The following is a description of a gene set: species: Homo sapiens from publication Coller HA, Grandori C, Tamayo P, Colbert T, Lander ES, Eisenman RN, Golub TR (PMID 10737792) MYC affects normal and neoplastic cell proliferation by altering gene expression, but the precise pathways remain unclear. We used oligonucleotide microarray analysis of genes and expressed sequence tags to determine changes in gene expression caused by activation of c-MYC in primary human fibroblasts. In these experiments, genes were consistently induced, and genes were repressed. The identity of the genes revealed that MYC may affect many aspects of cell physiology altered in transformed cells: cell growth, cell cycle, adhesion, and cytoskeletal organization. Identified targets possibly linked to MYC's effects on cell growth include the nucleolar proteins nucleolin and fibrillarin, as well as the eukaryotic initiation factor 5A. Among the cell cycle genes identified as targets, the G1 cyclin D2 and the cyclin-dependent kinase binding protein CksHs2 were induced whereas the cyclin-dependent kinase inhibitor p21(Cip1) was repressed. A role for MYC in regulating cell adhesion and structure is suggested by repression of genes encoding the extracellular matrix proteins fibronectin and collagen, and the cytoskeletal protein tropomyosin. A possible mechanism for MYC-mediated apoptosis was revealed by identification of the tumor necrosis factor receptor associated protein TRAP1 as a MYC target. Finally, two immunophilins, peptidyl-prolyl cis-trans isomerase F and FKBP52, the latter of which plays a role in cell division in Arabidopsis, were up-regulated by MYC. We also explored pattern-matching methods as an alternative approach for identifying MYC target genes. The genes that displayed an expression profile most similar to endogenous Myc in microarray-based expression profiling of myeloid differentiation models were highly enriched for MYC target genes. Human Gene Set: COLLER_MYC_TARGETS_UP Genes up-regulated in 293T (transformed fetal renal cell) upon expression of MYC., and this is the list of marker genes: GRPEL1, TRAP1, ASS1, POLR2H, HSPD1, G0S2, NCL, AK4, CKS2, FABP5, PPIF, ODC1, IARS1, C1QBP, SLC16A1, HDGF, FBL, EIF5A, CEBPZ, TFRC, NAMPT, CCND2, AHCY, GPI